Given this list of marker genes DDR1, TJP3, DUSP10, ARHGEF16, NEU1, CYB561, CDK16, AKT1, MVK, PMPCA, CLSTN1, CLDN3 (NCBI Gene Id 1365), PRKCD, TMED10, CDC34, BIK, BRMS1, MMP15, NECTIN2, NEDD8, GPX4, CORO1B, LASP1, SPINT1, RNF126, ADIPOR1, SYNJ2BP, SLC37A1, POR, TOLLIP, BSG, HNRNPAB, KCTD5, UBE2M, here is a description of the gene set: The Akt pathway is commonly deregulated in many cancers. Clinical trials are currently underway to test the effectiveness of breast cancer treatment by inhibition of various Akt pathway intermediates. A set of genes induced by Akt in a transgenic mouse model, a subset of which were sensitive to mammalian target of rapamycin (mTOR) inhibitor RAD001, was examined in five public gene expression profile data sets of clinical breast tumor specimens (representing >1000 different samples in all). In each of the clinical data sets, the Akt mouse model genes as a group were significantly overexpressed in human tumors having high levels of AKT1 mRNA. The subset of genes both upregulated by Akt and dependent on mTOR activity were associated with estrogen receptor-negative status, higher grade, increasing tumor size and poor prognosis in multiple patient cohorts; these associations were either not present or not as strong for the Akt-induced, mTOR-independent genes or for AKT1 expression alone. The genes shown here to be relevant to Akt-mTOR both experimentally and pathologically have the potential for use in a molecular diagnostic to determine which patients should receive mTOR antagonist treatment. from publication Creighton CJ (PMID 17213801) studied in species Homo sapiens Genes in the AKT1 pathway which are independent of MTOR, insensitive to RAD001 (everolimus). Human Gene Set: CREIGHTON_AKT1_SIGNALING_VIA_MTOR_UP